Given this list of marker genes Ccnb2, Map2k1, Ccnd1, Prkcd, Cdk4, Cd44, Ttf1, here is a description of the gene set: species: Mus musculus Genes detected by RT-PCR showing similar changes in lung adenomas and lung adenocarcinomas. Tissue is from lung adenoma from female A/J mice. Female A/J mice received a single i.p. injection of N-methylnitrosourea (MNU) in acidified saline (pH 5.0) at a dose of 50 mg/kg body weight. from publication Yao R, Wang Y, Lubet RA, You M (PMID 12173053) Mouse Gene Set: YAO_AJ_MOUSE_LUNG_TUMOR_PROGRESSION_SIMILAR_ADENOMA_UP